The following is a description of a gene set: species: Mus musculus Mouse Gene Set: GOBP_NEGATIVE_REGULATION_OF_URINE_VOLUME Any process that decreases the amount of urine excreted from the body over a unit of time., and this is the list of marker genes: Uts2r, Mllt6, Avpr2 (NCBI Gene Id 12000), Nfat5, Oxt, Adcy6, Uts2, Adrb1, Slc4a1, Slc5a2, Adrb2